Given this list of marker genes TBC1D24 (NCBI Gene Id 57465), ALX4, PIGO, TCF12, ATP6V1B2, here is a description of the gene set: Asymmetry of the anterior part of the skull. Anterior plagiocephaly Human Gene Set: HP_ANTERIOR_PLAGIOCEPHALY studied in species Homo sapiens